Given this list of marker genes CAPN1 (NCBI Gene Id 823), FOXS1, SHANK2, PRPF31, STOML1, RBM4, KCNIP2, RPL19, GDAP1L1, ATP6V1G2, PPP2R3C, LSG1, COL6A2, PAK6, RTTN, RNF208, FAM3A (NCBI Gene Id 60343), CORO1A, GGT7, WDR83OS, C5orf34, CCDC160, RAB13, DRC3, TBC1D22B, ZIK1, NCKAP5, NOSIP, PAK5, MPI, TRIQK, here is a description of the gene set: DNA methylation is essential for normal development and has been implicated in many pathologies including cancer. Our knowledge about the genome-wide distribution of DNA methylation, how it changes during cellular differentiation and how it relates to histone methylation and other chromatin modifications in mammals remains limited. Here we report the generation and analysis of genome-scale DNA methylation profiles at nucleotide resolution in mammalian cells. Using high-throughput reduced representation bisulphite sequencing and single-molecule-based sequencing, we generated DNA methylation maps covering most CpG islands, and a representative sampling of conserved non-coding elements, transposons and other genomic features, for mouse embryonic stem cells, embryonic-stem-cell-derived and primary neural cells, and eight other primary tissues. Several key findings emerge from the data. First, DNA methylation patterns are better correlated with histone methylation patterns than with the underlying genome sequence context. Second, methylation of CpGs are dynamic epigenetic marks that undergo extensive changes during cellular differentiation, particularly in regulatory regions outside of core promoters. Third, analysis of embryonic-stem-cell-derived and primary cells reveals that 'weak' CpG islands associated with a specific set of developmentally regulated genes undergo aberrant hypermethylation during extended proliferation in vitro, in a pattern reminiscent of that reported in some primary tumours. More generally, the results establish reduced representation bisulphite sequencing as a powerful technology for epigenetic profiling of cell populations relevant to developmental biology, cancer and regenerative medicine. species: Mus musculus Human Gene Set: MEISSNER_BRAIN_ICP_WITH_H3K4ME3 from publication Meissner A, Mikkelsen TS, Gu H, Wernig M, Hanna J, Sivachenko A, Zhang X, Bernstein BE, Nusbaum C, Jaffe DB, Gnirke A, Jaenisch R, Lander ES (PMID 18600261) Genes with intermediate-CpG-density promoters (ICP) bearing histone H3 trimethylation mark at K4 (H3K4me3) in brain.